The following is a description of a gene set: species: Mus musculus Mouse Gene Set: REACTOME_INTERLEUKIN_21_SIGNALING Interleukin-21 signaling, and this is the list of marker genes: Il21, Il21r, Stat5b, Stat5a, Stat3, Il2rg